Given this list of marker genes CTNNBIP1, MYC, HOXA7, ZBTB46, INPP5D, ZFP36L1, HLA-DRB1, CDK6, FES, APCS, CD4, FOXP1 (NCBI Gene Id 87246), MIR125B1, DCSTAMP, CSF1, ACIN1, IRF7, IL34, CD74, GPR68, here is a description of the gene set: Human Gene Set: GOBP_REGULATION_OF_MONOCYTE_DIFFERENTIATION species: Homo sapiens Any process that modulates the frequency, rate or extent of monocyte differentiation.